The following is a description of a gene set: Mouse Gene Set: GOMF_POLYPEPTIDE_CONFORMATION_OR_ASSEMBLY_ISOMERASE_ACTIVITY studied in species Mus musculus Catalysis of a reaction that alters the conformation or assembly of a polypeptide., and this is the list of marker genes: Dync1li1, Myo7b, Psmc4, Spast, Psmc1, Kif7, Kif22, Dnah3, Kif21a, Myh15, Myh4, Dnah8, Myo1f, Dnai2, Myo3a, Kif1b, Myo3b, Dnah11, Kif2a, Myh2, Kif6, Dnah5, Kif9, Kif3b, Myo1d, Dnah2, Kif11, Cenpe, Kifc1, Myo7a, Kif5b, Kif1a, Kif2b, Kif20b, Kif14, Myh11, Kif26a, Kif3c, Kif13a, Kif26b, Myo1g, Myo1e, Kif23 (kinesin family member 23), Myo15a, Myo9b, Myo10, Kif5c (kinesin family member 5C), Kif4, Myo9a, Myh8, Dnah6, Katnal1, Myh7b (NCBI Gene Id 674786), Kif16b, Kif27, Dync1i1, Kif15, Kif18b, Katnal2, Myo5c, Tnnt2, Dnhd1, Kifc3, Kif19a, Dnah12, Dnah17, Dync2h1, Myo5a, Dnah10, Psmc6, Dync1h1, Dnah14, Kif13b, Myo1c, Myh9, Cftr, Myh1, Kif1c, Kif20a, Kifc5b, Kif28, Fign, Myo6, Myl6, Myo5b, Kif12, Dnah1, Myh10, Dnah7c, Myo1a, Psmc5, Psmc2, Myo19, Kif24, Kif2c, Dnah9, Fignl1, Dnah7b, Kif18a, Myo1h, Actc1, Kif17, Kif21b, Kifc2, Dnah7a, Myh14, Myh7, Katna1, Kif19b, Kif5a, Kif3a, Myh3, Myo1b, Psmc3, Fignl2, Stard9, Myh6, Myh13